The following is a description of a gene set: from publication Kaji T, Ishige A, Hikida M, Taka J, Hijikata A, Kubo M, Nagashima T, Takahashi Y, Kurosaki T, Okada M, Ohara O, Rajewsky K, Takemori T (PMID 23027924) Human Gene Set: GSE11961_FOLLICULAR_BCELL_VS_GERMINAL_CENTER_BCELL_DAY40_DN species: Homo sapiens To obtain insight into the genetic basis of the increase of functional activity of memory B cells over time, we compared the gene expression profiles of day 7 and day 40 NP-specific/IgG1 memory B cells, GC B cells and plasma cells in immunized WT mice and naïve B cells, before and after activation in vitro. Genes down-regulated in follicular B cells versus day 40 germinal center B cells., and this is the list of marker genes: SIGIRR, TRIM67, KCTD20, RPS8, STXBP5, STK38, PABIR2, HES6, AVPR1B, SRMS, SH2D1B, NDE1, CIAO2A, GAL3ST1, FBXO7, AGRP, CBLL1, SLCO2B1, NMNAT1, TAF2, COA4, TCERG1, SLC27A3, SLC15A3, SCARB1, VWF, POLR2F, TRIM14, GCFC2, IL31RA, LRATD2, ATAD2B, SNAI3-AS1 (SNAI3 antisense RNA 1), RNASE2, DYNLL1, DLX1, CTSE, CDCP1, MRPL42, CHCHD3, SLAMF6, WDFY2, SNRNP25, HAUS8, CCDC12, UCP2, TLR7, PRR22, RILP, VRK2 (NCBI Gene Id 7444), GIT2, PGGT1B, EIF3I, HLX, RPL34, ICA1, NFYA, HNRNPLL, GPSM2, PTPRO, ACD, POLD1, CYBA, MICOS10, SLC6A4, AP4S1, LTB4R, KIAA0040, HROB, SH3TC1, CIB1, RPL10, IRF4 (interferon regulatory factor 4), PSD4, ATP5F1A, SCN4B, IFT57 (NCBI Gene Id 55081), SH3BGRL, PRKX, ERBB3, TMEM177, SUN2, IL36G, SUDS3, PPM1G, SLK, PARP2, SCAMP2, CD68, HMGCL, OTULIN, NINJ2, ANP32B, PPP1R21, AP5B1, F2RL2, ARHGEF7, ZNF653 (NCBI Gene Id 115950), ACOD1, PLIN5, ZSCAN2, SQLE, CORO1C, ACOX3, PKIB, GPR108, SIRPA, BCL2, NUCKS1 (nuclear casein kinase and cyclin dependent kinase substrate 1), KCNK6, PGK2, GALM, LAT2, CD5L, NASP, CCDC82, MYO9B, TAOK3, TREM2, SDHAF1, CSF2RA (colony stimulating factor 2 receptor subunit alpha), PIGQ, GM2A, IL36B, CADPS, ATP5PO, CASP3, PIK3R5, FEZF2, SH3BGRL3, WNT8A, FCHO1, ENOPH1, PPP1R14A, HEPHL1, MCMBP, PPAT, PPP1CA, HERC1, SLC2A6, HPS3, GALNT6, TYK2, LARP4B, AGPAT5, SREBF2, ANKH, CST3, CCDC88C, H3-5, UNCX, TF, HCST, MTMR14, IDH3B, REL, CCNB1IP1, CD37 (CD37 molecule), AKNA, TBC1D13, CYP27A1, KLHL6, ZFAND6, GNPDA1, MEAF6, PPP1R12C, ADAP1, ARL6IP1 (NCBI Gene Id 56166), EXOSC5, RPS25, HRH1, TET2, WDHD1, MAPK14, ITGA4, GMPR2, ARPC2, RIF1, NCF1, TSPAN13, INTS5, TMEM71, VCPKMT, PDCD2L, SSC4D, EPB41, ZFYVE26, NCCRP1, PFN1, ALS2CL, WDFY4, GALNT7, ARMC7, GLT6D1, RAD54L, CCL22, ATP6V0E2, PTPRC, CENPS, TREML4